Given this list of marker genes RBBP4, ANXA3, PTGES3, PAPOLA, HPRT1, CXCL1, UBE2E1, TPGS2, RECQL, CITED2, TMED7, JUND, HSD17B8, TAGLN3, UBE2D3, ACKR2, MAP2K1, ANAPC15, CDK1, NAP1L1, TOB1, ANXA2, PDIA6, CCNC, PRKAR1A, PSMD8, TACSTD2, KYNU, SRSF1 (NCBI Gene Id 650453), SCFD1, TM2D1, PTGS2, FOS, IL6, PLSCR1, RIDA, ADK, KYAT3, DSG2, RRM2, SH3BGRL, MIR22HG, CXCL8, AGL, TNF, CCL20, RALB, SCARB2, B2M, GADD45A, ME2, RFC5, ARHGDIB, HEXIM1, DYNLT3, AP4S1 (adaptor related protein complex 4 subunit sigma 1), TSC22D3, EIF2S3, ATP5F1A, HSP90AB1, PFDN6, CXCL3, SSR1, ALDH7A1, PGK1, YWHAZ, SKP1, IL1B, RCN2, MYCBP, SRI, NEK4, AP1S2, TWF1 (NCBI Gene Id 82712), GLUD2, H2BC12, ITM2B, CDKN1C (NCBI Gene Id 702), UQCRC2, RAD51C, PMAIP1, IGFBP7, SRSF10 (NCBI Gene Id 89048), SNX3, SLC11A1, IL13RA1, SSBP1, LAMP2, SDHD, TAF2, SEPTIN10, RTN4, SLC25A46, CTCF, UPK1B, ID2, COPB1, CXCL2, CSF2, CORT, ATP6AP2, AIMP1, ATF3, PRDX3, DYNC2LI1, here is a description of the gene set: species: Homo sapiens Human Gene Set: DAZARD_RESPONSE_TO_UV_SCC_UP To gain insight into the transformation of epidermal cells into squamous carcinoma cells (SCC), we compared the response to ultraviolet B radiation (UVB) of normal human epidermal keratinocytes (NHEK) versus their transformed counterpart, SCC, using biological and molecular profiling. DNA microarray analyses (Affymetrix), approximately genes) indicated that the major group of upregulated genes in keratinocytes fall into three categories: (i). antiapoptotic and cell survival factors, including chemokines of the CXC/CC subfamilies (e.g. IL-8, GRO-1, -2, -3, SCYA20), growth factors (e.g. HB-EGF, CTGF, INSL-4), and proinflammatory mediators (e.g. COX-2, S100A9), (ii). DNA repair-related genes (e.g. GADD45, ERCC, BTG-1, Histones), and (iii). ECM proteases (MMP-1, -10). The major downregulated genes are DeltaNp63 and PUMILIO, two potential markers for the maintenance of keratinocyte stem cells. NHEK were found to be more resistant than SCC to UVB-induced apoptosis and this resistance was mainly because of the protection from cell death by secreted survival factors, since it can be transferred from NHEK to SCC cultures by the conditioned medium. Whereas the response of keratinocytes to UVB involved regulation of key checkpoint genes (p53, MDM2, p21(Cip1), DeltaNp63), as well as antiapoptotic and DNA repair-related genes - no or little regulation of these genes was observed in SCC. The effect of UVB on NHEK and SCC resulted in upregulation of 251 and genes, respectively, and downregulation of genes in NHEK and genes in SCC. To further analyse these changes, we used a novel unsupervised coupled two-way clustering method that allowed the identification of groups of genes that clearly partitioned keratinocytes from SCC, including a group of genes whose constitutive expression levels were similar before UVB. This allowed the identification of discriminating genes not otherwise revealed by simple static comparison in the absence of UVB irradiation. The implication of the changes in gene profile in keratinocytes for epithelial cancer is discussed. Genes up-regulated in SCC12B2 cells (squamous cell carcinoma) by UV-B irradiation. from publication Dazard JE, Gal H, Amariglio N, Rechavi G, Domany E, Givol D (PMID 12771951)